The following is a description of a gene set: studied in species Homo sapiens Human Gene Set: GOBP_NEGATIVE_REGULATION_OF_MUSCLE_CONTRACTION Any process that stops, prevents, or reduces the frequency, rate or extent of muscle contraction., and this is the list of marker genes: IRAG1, PRKG1, GUCY1A1, RGS2, ATP1A2, MIR30E, SOD1, STUB1, GRK2, PIK3CG, ARHGAP42, ADRB2, DOCK4, ZC3H12A, ADORA2B, CALCA, ATP2A1, ADCY10, MIR153-1, DOCK5, SRI, ADRA2A, BIN1, TNNT1